Given this list of marker genes CDCP1, C3orf18, RNF38, RASSF1, PAGR1, UBE2G1, UBTD1, FZD7, WDR26, SH2D4A, BORA, CDC42SE1, PTPN7, HENMT1, MORC2, L3MBTL3, FJX1, NFIX, CNOT2, ELOVL6, SLC35E1, PLEKHN1, LINC02693, COPZ1, PRSS35, TMEM123, SMPD3, MAN2A2, NCSTN (NCBI Gene Id 57297), TMEM38A, UBN2, MRAS, EPB41, ZMYND11, PCDH17, CDK16, TMEM121B, MECOM, TP53INP1, NRF1, ASXL1, KCNK2, DUSP3, GMIP, SPRY4, CEP170, TENT4B (terminal nucleotidyltransferase 4B), CTDSPL, CNOT6, PDCL, TP53RK, GOLGA3, MAPRE2, COPS4, CXXC4, MMP24, here is a description of the gene set: Genes predicted to be targets of miRBase v22 microRNA hsa-miR-4725-5p in miRDB v6.0 with MirTarget v4 prediction scores > 80 (high confidence targets). species: Homo sapiens Human Gene Set: MIR4725_5P from publication Chen Y, Wang X (PMID 31504780)